The following is a description of a gene set: species: Homo sapiens Areas of brighter than expected signal on magnetic resonance imaging emanating from the cerebral white matter that surrounds the cerebral ventricles. Periventricular white matter hyperintensities Human Gene Set: HP_PERIVENTRICULAR_WHITE_MATTER_HYPERINTENSITIES, and this is the list of marker genes: RAB3GAP2, GM2A, SELENOI, AP5Z1, TRPM3, ACTA2, CNKSR2, DDHD2, ABCC9, CNP, STRADA, ARSA, MMACHC, ABHD16A, PRORP, RPL10, GNB2, PSAP, ACTL6B, PAK1, NEUROD2, CNBP, TMEM222, SPG21